Given this list of marker genes Myc, Ccnd2, Caprin1, Ccnd1, Mir193a, Mvp, G3bp1, here is a description of the gene set: mir-193a and MVP in colon cancer metastasis studied in species Mus musculus Mouse Gene Set: WP_MIR193A_AND_MVP_IN_COLON_CANCER_METASTASIS